Given this list of marker genes EPHA5, UBE2V1, TCF19, ATF7, CACHD1, WWC3, PDPK1, LZTS3, ZHX3, TNPO1, DDX3X, ESRRB, LRIG3, PPP3R1, UBE2G1, SDK2, VSTM4 (NCBI Gene Id 196740), ZNF704, DPP8, CFL2, SLC34A1, CHAD, PALM2AKAP2, SSR1, CDK16, DNASE2, BEAN1, GPR137, PLPPR2, CDH17, GATAD2B, ZBTB20, ONECUT1, RYBP, FOXN3, DEF8, SPMIP5, GAPT, EFS, DGKI, JPH4, FBXL18, ESRRG, FIGN, GDF6, PEA15, PHB1 (prohibitin 1), CCDC174, MTCL2, ZNF609, TBL1Y, AP1M2, KDM6A, KCNS1, EPHA8 (EPH receptor A8), STIM1, MAP1B, SH2B3, BIRC6, PRKD3, ZNF608, CCSER2, FOXN2, NR6A1, NDRG1, TEAD3, MEF2C, ADRM1, RUNDC3A, ATXN1, KCNJ6, BARD1, RGS9BP, FAM53A, EEF1A1, TLN1, KCNH5 (potassium voltage-gated channel subfamily H member 5), TRIO, ATM, WASF2, SSH2 (slingshot protein phosphatase 2), TPPP3, HTR6, FMNL2, CTNNA2, BAZ2A, PTPN12, ATP9A (ATPase phospholipid transporting 9A (putative)), MYO5C, GID4, LRRC59, PRODH, INHBB, SAMSN1, ST7L, KLHL12, HABP4, CDKAL1, CHID1, PLEC, TNKS, STAG1, ASIC2, NCKAP1, TPP1, FBH1, CYP3A5, CACNB4, TRAF3IP3, ZFP41 (ZFP41 zinc finger protein), ATG9A, here is a description of the gene set: Human Gene Set: MIR4736 from publication Chen Y, Wang X (PMID 31504780) Genes predicted to be targets of miRBase v22 microRNA hsa-miR-4736 in miRDB v6.0 with MirTarget v4 prediction scores > 80 (high confidence targets). studied in species Homo sapiens